The following is a description of a gene set: from publication Chen Y, Wang X (PMID 31504780) Human Gene Set: MIR370_5P Genes predicted to be targets of miRBase v22 microRNA hsa-miR-370-5p in miRDB v6.0 with MirTarget v4 prediction scores > 80 (high confidence targets). species: Homo sapiens, and this is the list of marker genes: SCOC, PPFIBP1, UBE2K, LUC7L3, TMPRSS11E, CTPS1, CCDC85C, GRIP1, PLEKHA3, MARCHF9, MSL1, FZD3, NLN, BACH2, EP400, CALCR, SZRD1, MFSD6, NIPSNAP2, NEK2, MTF2, KPNA3, NHLH2, SLC1A2, NELL1, KHDRBS2, USP30, SEMA4F, TTC39C, CACNB3, SCAMP3, PCSK2, ANKRD17, EDEM3, KLF4, SPDYA, MTMR6, KHNYN, KLHL4, PRPH, TAF9B, CACNA2D1, RFX7, LRRC58, DPY19L3, FAM241B, DCAF10, USP48, CDV3, DDIT4L, C10orf88, SMAD4, ADAMTS5, NR1D2, CCDC57, ZMAT3, HIP1, AP4E1, MECOM, CDNF, SPATA6, IRF6, ILF2, OBSL1, GLRB, DNAJC30, ING2, ZNF746, HAPSTR1, EFNA5, AAGAB, POFUT1, PURB, GSDME